Given this list of marker genes SMAD3, SMAD2, SMAD4, here is a description of the gene set: studied in species Homo sapiens Reactome Pathway: Loss of Function of SMAD4 in Cancer SMAD4 was identified as a gene homozygously deleted in ~30% of pancreatic cancers and was named DPC4 (DPC stands for deleted in pancreatic cancer). SMAD4 maps to the chromosomal band 18q21.1, and about 90% of pancreatic carcinomas show allelic loss at chromosomal arm 18q, while ~50% of pancreatic cancers show some alteration of the SMAD4 gene.<br><br>Based on COSMIC database (Catalogue Of Somatic Mutations In Cancer), mutations in the coding sequence of SMAD4 gene are frequently found in pancreatic cancer, biliary duct carcinoma and colorectal cancer. Germline SMAD4 mutations are the cause of juvenile polyposis, an autosomal dominant disease that predisposes affected individuals to hamartomatous polyps and gastrointestinal cancer. Homozygous Smad4 loss is embryonic lethal in mice. Smad4 +/- heterozygotes appear normal but develop intestinal polyps between 6 and12 months of age and these polyps can progress to cancer. Loss of the remaining wild-type Smad4 allele is detectable only at later stages of tumor progression in Smad4+/- mice. Compound Apc+/-;Smad4+/- mice develop malignant tumors from intestinal polyps more rapidly than Apc+/- mice.<br><br>SMAD4 coding sequence mutations are most frequently found in the MH2 domain and impair the formation of SMAD4 heterotrimers with phosphorylated SMAD2 and SMAD3, thereby impairing SMAD4:SMAD2/3 heterotrimer-mediated transcriptional regulation of TGF-beta responsive genes. MH2 domain is also involved in the formation of SMAD4 homotrimers which may play a role in SMAD4 protein stability.<br><br>Coding sequence mutations are also found in the MH1 domain of SMAD4. MH1 domain is involved in DNA binding and it is also involved in the formation of SMAD4 homotrimers. part of: Signaling by TGF-beta Receptor Complex in Cancer